The following is a description of a gene set: species: Homo sapiens from publication Chen Y, Wang X (PMID 31504780) Human Gene Set: MIR5689 Genes predicted to be targets of miRBase v22 microRNA hsa-miR-5689 in miRDB v6.0 with MirTarget v4 prediction scores > 80 (high confidence targets)., and this is the list of marker genes: AMD1, HNRNPK, EPHA3, TNRC6B, MAML2, MYEF2 (NCBI Gene Id 56051), PAX4, SLC16A7, CASZ1, KLF13, HECTD1, ARRDC4, PPP3CB, TRIM33, GNAI1, ZNF594, AMBN, ACVR2A, RECK, PAIP1, HK1, UBE2E3, AFF4, C9orf40, STX16, PANK1, ZNF780A, PTPRB, SNX18, HTRA1, SEMA6D, PRRT2, SMAD1, TET1, BCL11A, ACVR1C, BRINP2, SATB1, ZFR, EGR2, PRR16, WSB1, UBE2D1, PRRG1, PKP4, TBPL1, TMTC3, MOB4, DAB2, TMEM168, FAM168B, ACSL3, SGO1, IRF2BP2, RAD51C, AMACR, PIGA, ZNF644, CHML (NCBI Gene Id 1122), VEZF1, TACC2, BPTF, PLS1, MYT1L, TOGARAM1, NCK1, MEF2C, TSPYL1, EHD3, TXLNG, RERGL, CWC27, TAF1, CNIH4, FAM168A, SH3BGRL, UTS2B, AMPH, DESI2, DACH1, ARF6, SLC25A53, NRIP1, GALK2, GATA2, FMR1, UBFD1 (NCBI Gene Id 56061), RHOH, NPTX1, ATF1, ATP11A, ELMOD1, DR1, MAST4, PPM1B, TEX101, LRRC1, UTRN, GABRA6, JMJD1C, UBR5, SAMD12, STEAP3, KRTAP2-3, COPS2, ENOPH1, MOSPD1, CCN4, LDB2, LYSMD3, LCLAT1, ARAP2, LINC01517, DCHS2, FAM120A, FOXO3, CKAP2 (cytoskeleton associated protein 2), PTPN12, TASOR, RNF6, IKZF5, TMED4, ITGBL1 (NCBI Gene Id 9358), CHST11, ZNFX1, TAB3, SOCS5, OTX2, KYAT3, PRXL2C, LPAR1, NR4A3, CLOCK, RBM47, AP3B1, NAPEPLD, MSI2, GAS1, BACH2, ZSCAN4, CTDSPL2, SEMA4F, PTK7, CARMIL1, IL1RAP, NFYB, SLC39A10, PUDP, MAP9, PPP4R3B, CTNNA2, KALRN, ADAM23, FGF12, TSHZ1 (teashirt zinc finger homeobox 1), LMO4